The following is a description of a gene set: studied in species Homo sapiens Human Gene Set: GOMF_RAGE_RECEPTOR_BINDING Binding to a RAGE receptor, the receptor for advanced glycation end-products., and this is the list of marker genes: FPR2, S100A4, HMGB2, FPR1, S100A13, S100B, APP, S100A12, S100A7, HMGB1, S100A8, S100A9